The following is a description of a gene set: BRCA2 (FANCD1) is a tumor suppressor gene located on chromosomal arm 13q. BRCA2 protein is a mediator of the core mechanism of homologous recombination repair (HRR), essential for the recruitment of RAD51 recombinase to resected DNA double-strand breaks (DSBs). Monoallelic pathogenic germline mutations in BRCA2 are one of the underlying causes of the hereditary breast and ovarian cancer (HBOC) syndrome, with carriers having close to 50% lifetime risk for development of breast cancer and about 15% lifetime risk for development of ovarian cancer. In addition, BRCA2 germline mutation carriers are predisposed to cancers of the fallopian tube, pancreas, stomach, larynx and prostate. Biallelic germline mutations in BRCA2 cause Fanconi anemia subtype characterized by brain and soft tissue tumors, including medulloblastoma and Wilms tumor. BRCA2-deficient cells are defective in the formation of RAD51 foci upon treatment with DSB-inducing DNA damaging agents and accumulate chromatid breaks and radial chromosomes.<br><br>Besides its crucial role in HRR, BRCA2 is also implicated in protection of replication forks, centrosome duplication, spindle assembly checkpoint and cytokinesis. Recently published studies show the involvement of BRCA2 in the turnover of R-loops (hybrids between RNA and single strand DNA that are generated as intermediates of gene transcription). Unscheduled accumulated R-loops may be processed into DSBs, leading to genomic instability. Finally, BRCA2 is involved in pathway choice of DSB repair by inhibiting DNA polymerase theta-mediated end-joining (TMEJ) until M-phase. TMEJ is the predominant pathway for microhomology-mediated end joining MMEJ/alternative-nonhomologous end joining (alt-NHEJ, a-EJ) in mammals.<br><br>BRCA2 haploinsufficiency is frequently observed in cancers, with close to 50% of BRCA2-mutant breast cancers retaining one wild type allele, suggesting that in some tissues at least heterozygous loss of BRCA2 function is sufficient for carcinogenesis. Promoter hypermethylation is not an obvious contributor to BRCA2 gene inactivation and no pathogenic mutations in the promoter region have been identified so far.<br><br>For review, please refer to Roy et al. 2011, Nalepa and Clapp 2018, Santana dos Santos et al. 2018, Venkitaraman 2019, Le et al. 2021, and Llorens-Agost et al. 2021. part of: Diseases of DNA Double-Strand Break Repair Reactome Pathway: Defective homologous recombination repair (HRR) due to BRCA2 loss of function species: Homo sapiens, and this is the list of marker genes: NBN, RAD51B, BLM, PALB2, EXO1, BRIP1, RAD1, RAD9B, RFC3, ATM, RHNO1 (RAD9-HUS1-RAD1 interacting nuclear orphan 1), BRCA2, RAD50, RPA3, BARD1, TOP3A, ATRIP, RAD51D, RMI1, WRN, RPA1 (replication protein A1), RFC2, KAT5, XRCC2, ATR, HUS1, RBBP8, RFC4, DNA2, RMI2, RAD51, MRE11, BRCA1 (BRCA1 DNA repair associated), RAD51C (RAD51 paralog C), RAD51AP1, RPA2, RAD17, RFC5, RAD9A, SEM1, TOPBP1